Given this list of marker genes TTN, ALG14, BIN1, TGFB3, MYPN, OPA1, PSMB8, DYSF, DSTYK, MEG3, GDF3, TRPV4, RPS27, ALG2, FRG1, GSC, RPL18, FILIP1, EYA1, RPS19, KLHL41, DPAGT1, GNE, EBF3, TBX2, RPS10, SGCB, RPL5, SYNE1, VWA1, PRR12, SF3B4, TPM3 (tropomyosin 3), LAMB2, ORC1, RPS24, OBSL1, COL11A1, ANO5, RPS29, TRIP11, MEOX1, EMD, WNT3, SPEG, DYM, POMT2, TBX3, LEMD3, PTCH1, SGCG, FIG4, C19orf12, DLK1, LRIF1, DUX4 (NCBI Gene Id 649941), SOST, VAC14, TPM2, FHL1, COL2A1, TWNK, EXT1, SCN4A, LYSET, TBX5, FLNB, ADA, CSGALNACT1, RPS28, CAPN3 (calpain 3), RPL11, RPS7, TNPO3, TMEM43, TNNT1, SLC35D1, RYR3, RIPK4, PAX1, CDH2, GPX4, HSPG2, RPL9, INPPL1, KCNJ2, GMPPB, RSPO2, KBTBD13, COL11A2, SMPX, SPRED2, ADA2, ACTB, RUNX2, RAF1, POR, SQSTM1, EMILIN1, SOX9, PYROXD1, SGCD, COL6A1, RPS20, DNMT3B, FGFR2, COLQ, RTL1, FGFR1, GDF11, POGLUT1, SGCA (sarcoglycan alpha, NCBI Gene Id 6442), COL12A1, TRIO, COL3A1, PTPN11, CUL7, CRPPA, TSR2, SEPTIN9, COL6A3, BAG3, FBN1, LBR, WBP11, NEB, SYNE2, GDF6, RYR1, RPL26, CCDC8, PLIN4, ASH1L, ACTA1, DUX4L1, HEATR3, GNPTAB (NCBI Gene Id 79158), NPR2, TBX15, SMCHD1, RPS17, FLNA, GYG1, MYH7, ANXA11, BICD2, GATA1, BRAF, LGI4, MAP3K7, RPS26, RPL15, VCP, ATP6V0A2, PUS1, LMX1B, POLG, COL6A2, EFNB1, NSDHL, TMCO1, RPS15A, PCNT, MYBPC1, DNM1L, SCARF2, FGFR3, RPL8, WDR35, EXT2, LMNA, TRPS1, TK2, PAX3, SPTLC1, RPL31, FLNC, RPL35A, NEFL, RPL35, RPL27, GFPT1, MYH2, here is a description of the gene set: Human Gene Set: HP_ABNORMAL_SCAPULA_MORPHOLOGY Abnormal scapula morphology Any abnormality of the scapula, also known as the shoulder blade. species: Homo sapiens